The following is a description of a gene set: Genes predicted to be targets of miRBase v22 microRNA mmu_miR_1954 in miRDB v6.0 with MirTarget v4 prediction scores > 80 (high confidence targets). Mouse Gene Set: MIR_1954 from publication Chen Y, Wang X (PMID 31504780) studied in species Mus musculus, and this is the list of marker genes: Slc12a7, Mfsd3, Lin7a, Slco5a1, Lrrc14, Dnajc25, Hace1, Ino80d, Irx1, Nadk2, Eya1, Psen2, Asap2, Podn, Pkm, Fzd1, Dner, Igsf3, Zfp945, Rab30, Itga9, Nkain2, Oga, Dock5, Ptpn2, Cyb561a3, Xpnpep3, Slc40a1, Adam7, Rap1gds1, Nipbl, Klk7, Tpd52l2, Nebl, Itpripl2, Ube2b, Hacd2, Myt1l, Rbl1, Loricrin, Yy2, Trub2, Cds2, Ppp1r16b, Clic5, Sytl4, Fcer1a, Dst, Rnf17, Zfp609, Plch1, Map2k4, Spink6, Ppp4r3a, Pknox1, Rpp14, Cnot7, Wsb1, Ubl3, Cdh17, Camta1, Rdh1, Hs3st3b1, Slc35f6, Gvin1, Rab3b, Glud1, Noc2l, Syn3 (NCBI Gene Id 27204), Etv1, Col12a1 (collagen, type XII, alpha 1), Ell2, Gvin2 (GTPase, very large interferon inducible, family member 2), Sntg1, Il1r1, Enc1, Pde2a, Slc45a4, Sema5a, Epha4, Cd300lg, Atf2, Srsf7, Fam43b, Khdc4, Maea, Ppm1f, Ston2, Rap2c, Tmem38b, Poldip2, Pacs2, Rpgrip1l, Arhgap17, Ankrd10, Usp9x, Paip2, Neurl1a, Rpl13a, Plekhf2, Cdcp2, Zfp729b, Ppp1r3d, Camsap2, Adam22, Myh4, Pwp2, Fut10, Fign, Fam98a, Tnrc6b, Ccdc126, Il10ra, Stk3, Pappa, Nufip2, Reep1, Samd11, Wdr47, Cpeb4 (NCBI Gene Id 67579), Sufu, Anks6